Given this list of marker genes ECHS1, ACADM, HADH, HADHB, HADHA, here is a description of the gene set: species: Homo sapiens Reactome Pathway: Beta oxidation of octanoyl-CoA to hexanoyl-CoA part of: mitochondrial fatty acid beta-oxidation of saturated fatty acids The fifth pass through the beta-oxidation spiral picks up where the last left off with the saturated fatty acid octanoyl-CoA and produces hexanoyl-CoA. Four enzymatic steps are required starting with MCAD CoA dehydrogenase (Medium Chain) activity, followed by the enoyl-CoA hydratase activity of crotonase, the 3-hydroxyacyl-CoA dehydrogenase activity of the short chain 3-hydroxyacyl-CoA dehydrogenase (SCHAD), and completed by the ketoacyl-CoA thiolase activity, present in the mitochondrial membrane associated trifunctional protein.